The following is a description of a gene set: from publication Rashi-Elkeles S, Elkon R, Weizman N, Linhart C, Amariglio N, Sternberg G, Rechavi G, Barzilai A, Shamir R, Shiloh Y (PMID 16314843) The ATM protein kinase, functionally missing in patients with the human genetic disorder ataxia-telangiectasia, is a master regulator of the cellular network induced by DNA double-strand breaks. The ATM gene is also frequently mutated in sporadic cancers of lymphoid origin. Here, we applied a functional genomics approach that combined gene expression profiling and computational promoter analysis to obtain global dissection of the transcriptional response to ionizing radiation in murine lymphoid tissue. Cluster analysis revealed a prominent pattern characterizing dozens of genes whose response to irradiation was Atm-dependent. Computational analysis identified significant enrichment of the binding site signatures of NF-kappaB and p53 among promoters of these genes, pointing to the major role of these two transcription factors in mediating the Atm-dependent transcriptional response in the irradiated lymphoid tissue. Examination of the response showed that pro- and antiapoptotic signals were simultaneously induced, with the proapoptotic pathway mediated by p53 targets, and the prosurvival pathway by NF-kappaB targets. These findings further elucidate the molecular network induced by IR, point to novel putative NF-kappaB targets, and suggest a mechanistic model for cellular balancing between pro- and antiapoptotic signals induced by IR in lymphoid tissues, which has implications for cancer management. The emerging model suggests that restoring the p53-mediated apoptotic arm while blocking the NF-kappaB-mediated prosurvival arm could effectively increase the radiosensitivity of lymphoid tumors. Human Gene Set: RASHI_RESPONSE_TO_IONIZING_RADIATION_5 Cluster 5: early responding genes activated in ATM deficient but not in the wild type tissues. species: Mus musculus, and this is the list of marker genes: TMEM229B, TXNRD2, DNAJB2, RCC1, TAF1B, ETFBKMT, SERPINB9, EXOSC8, DNAJB4, URM1, ZBTB47, R3HDM1, INVS, LLGL2, ZFP30, PDE8A, CD93, PIK3R1, MAP3K4 (mitogen-activated protein kinase kinase kinase 4, NCBI Gene Id 4216), NFIA, ACBD6, ANP32A, PALM2AKAP2 (PALM2 and AKAP2 fusion), HMGCL, EVI5, DDX41, DPPA4, COL13A1, SHMT1, P4HB, NACC2, LARP7, F2RL1, PCSK5, GRB10, BMPR1A, FRAT1, FAM53A, DNAJC5, TCF20, CFHR1, PAK3, CDC6, CSNK2A1, MAP3K7, VAMP2, SERPINE1, CD180, TOMM34, SPATA6, PEX5, FAM118B, AP5S1, GALT, SH3BP5, COL14A1, TFAP2A, THBS2, SMR3B, EPHA4, KLF13, SH3GL3, ESYT3, GIPC2, TOMM6, CYP2A6, EIF2AK2, ADORA2A, DLAT, EMCN, DNMT3A, CPOX, SURF6, RAP2B, MAP4K4, CYTH3, IGLL5, MRPL17, NCOA2, CASP8, SLMAP, KRT12, CRK, ZBTB14, PRLR, RNF7, PLK1, PAX1, NFIX, CHTF8, ATP13A3, SMARCC1, INHBC, GAS7, DEAF1, BCAS2, ZNF787, UCHL5 (NCBI Gene Id 82736), DPT, CHAF1B, RXYLT1, NAA40, SNX17, PELO, ERI2, EEF1A2, FASTK, F5, ANG, CIB1, HERC2 (NCBI Gene Id 8924), PPP1R3C, CYP2C8, STC2, RNF225, F7, HSDL2, PREPL, KSR1, IQGAP3, GPR33, VHL, TDO2, KCNJ8, INHBA, CNOT6L, ATN1, GSTM5, GADD45G, EPB41, TMEM170A, DSG2, USP7, DAB2IP